The following is a description of a gene set: studied in species Homo sapiens Human Gene Set: GSE37301_HEMATOPOIETIC_STEM_CELL_VS_LYMPHOID_PRIMED_MPP_DN from publication Ramirez K, Chandler KJ, Spaulding C, Zandi S, Sigvardsson M, Graves BJ, Kee BL (PMID 22608498) Expression profiling of Rag2-deficient Ets1++ and Rag2-deficient Ets1-- mature NK cells and WT bone marrow progenitors, WT T cells, and WT Pro B cells Genes down-regulated in hematopoietic stem cells versus lymphoid primed multipotent progenitors., and this is the list of marker genes: KCNK5, RELT, P4HA3, GSTA3, IQCF3, PXK, IFIT1, PEX16, PSMC6, TMED1, GTF2E2, TSPO, KDM4A, VCP, RNMT, RTCA, MIR451A, USP2, ARHGAP35, ZRANB2, MTRR, COX17, SPN, IFTAP, H1-9P, PTPN2, SYVN1, CRYZL2P, SNCAIP, NUP54, ARID5B, TRIM21, RAB21, TMEM167A, MIX23, TIMD4, PSMD3, ACVR1, MRPL45, HTRA1, BTBD19, STXBP1, SLC25A33, GLT6D1, SLC25A29, SLC38A6, PSMA2 (NCBI Gene Id 5683), SLC48A1, FKBP2, SGSM1, MIR191, UTP20, CCL22, CYB5R3, PFN1, PLS3, ALPK2, ZHX2, COPS8, OSGIN2, EIF4E, CERS6, GPR174, MIA, PKP2 (plakophilin 2), HSPA13, COX7A2, PSMC5, HSPH1, ENO2, FKBP9, PTPN11, MRPL21, IL12B, CCT2, ELOC, BID, LCP1 (lymphocyte cytosolic protein 1), EZR, NTAQ1, STRIP1 (striatin interacting protein 1), PAPSS1, UNC5C, SMTNL2, PLP1, ARFGAP3, ITPRIPL2, PSME3, VCAN, BCL2L2, UEVLD, IRF7, BNIP2, KCTD1, PALLD, MAN2A1, PGAP2, CHIC2, LPAR1, MTDH, GPATCH11, GSTP1 (NCBI Gene Id 2950), RAB10, NQO1, DNAJB1 (NCBI Gene Id 3337), PHLDB2 (NCBI Gene Id 90102), CRY1, TUBG1, PGD, SLC30A6, SLC3A2, MVP, RAD17, ALG12, KRTCAP2, SLAMF1, C18orf32, SRM, AK2, BPNT1, SNX17, GTF2H3, CD47, TMCO4, ABTB2, GSTM2, PWP2, PAPSS2, IRF2BP2, ITGB1, STK38, GTF2H4, LSM2 (NCBI Gene Id 57819), PPM1M, MYO1B, AFAP1, TWSG1, MRPL35, SCHIP1, CKS1B, CYCS, RPL24, RDH12, EID3, FBXO30, SLC16A10, CAMKK1, PTGR3, ARMH3, PCDH7, TMEM68, PARP3, MACROH2A1, YRDC, TPBG, PPP1R14B, CYTH2, TAF15, SNRPA1, MAGT1, PCP4 (Purkinje cell protein 4), BEND6, MAPK8IP2, TMPRSS6, NKIRAS1, CINP, WFDC21P, DRAXIN, PICALM, TMA16, DNAAF6